The following is a description of a gene set: Catalysis of the reaction: ATP + creatine = N-phosphocreatine + ADP + 2 H+. Mouse Gene Set: GOMF_CREATINE_KINASE_ACTIVITY studied in species Mus musculus, and this is the list of marker genes: Ckm, Ckmt2 (NCBI Gene Id 76722), Ckmt1, Map4k4, Ckb